The following is a description of a gene set: Mouse Gene Set: GOBP_GLAND_MORPHOGENESIS The process in which the anatomical structures of a gland are generated and organized. species: Mus musculus, and this is the list of marker genes: Stat5a, Twsg1, Msx2, Src, Sox9, Hoxd13, Rln1, Slit2 (NCBI Gene Id 338531), Slc12a2, Mmp2, Wnt4, Mdk, Foxa1, Rxfp1, Xbp1, Lama5, Ar, Ifng, Pax3, Ptn, Ddr1, Wnt3a, Nkx3-1, Rtn4 (reticulon 4), Il18, Pml, Bmp4, Rarg, Hpn, Pgr, Cul3, Ccl2, Plxna1, Sulf1, Cebpb, Tgm2, Sema3c, Prop1, Tnf, Etv5, Dag1, Serpinb5, Esr2, Elf3, Lrp6, Zfp157, Nog, Fgfr1, Plag1, Smo, Igfbp5, Rxra, Tbx3, Rps6ka1, Itpr1, Tfap2c, Lims1, Plxnd1, Gli1, Stat6, Nrg3, Esrp1, Esr1, Fgl1, Fgf18, Hoxa13, Fgfr2, Cpb2, Gdf7, Etv4, Perp, Sema3a, Ctnnd1, Epha2, Hgf, Shh, Bcl2, Pdgfb, Snai2, Cflar, Lama1, Fgf1, Cav1, Tgfa, Trp63, Mki67, Tgfb2, Btrc, Bax, Plau, Cdkn2a, Eda, Fgf10, Robo1, Ntn4, Gli3, Nfkb1, Bmp7 (bone morphogenetic protein 7), Notch2, Pax6, Nfib, Duox2, Vdr, Lims2, Pthlh, Sostdc1, Btbd7, Areg, Edar, Ceacam2, Wnt5a, Id4, Nkx2-3, Prox1, Mst1 (macrophage stimulating 1 (hepatocyte growth factor-like)), Tnc, Notch1, Hoxb13, Met, Polb, Cdc42, Fgf8, Lrp5, Cav3, Med1, Msn, Tnfaip3 (NCBI Gene Id 21929), Ntn1, Pdgfa, Nrp1, Tgfb1, Ncoa3, Tet2, Egfr, Ceacam1, Frs2, Gli2, Fem1b, Il6 (interleukin 6), Tgfbr2, Tgfb3, Sulf2, Igf1r, Phb2, Cyp7b1, Cdh1, Nr3c1, Nherf1, Sfrp1, Fgf7, Tbx2, Cd44, Kdm5b, Csf1, Lipa, Csmd1, Capn1, Ccl11, Igf1, Esrp2, Bsx, Scrib, Ptch1